The following is a description of a gene set: Catalysis of the transfer of a oligosaccharyl group to an acceptor molecule, typically another carbohydrate or a lipid. species: Homo sapiens Human Gene Set: GOMF_OLIGOSACCHARYL_TRANSFERASE_ACTIVITY, and this is the list of marker genes: STT3A, STT3B, RPN1, RPN2, OSTC